The following is a description of a gene set: species: Mus musculus Mouse Gene Set: CUI_T_CELL_CD4_BAFF_RESPONSE_DN from publication Cui A, Huang T, Li S, Ma A, Pérez JL, Sander C, Keskin DB, Wu CJ, Fraenkel E, Hacohen N (PMID 38057668) Cytokines mediate cell-cell communication in the immune system and represent important therapeutic targets. A myriad of studies have highlighted their central role in immune function, yet we lack a global view of the cellular responses of each immune cell type to each cytokine. To address this gap, the authors created the Immune Dictionary, a compendium of single-cell transcriptomic profiles of more than 17 immune cell types in response to each of 86 cytokines (>1,400 cytokine-cell type combinations) in mouse lymph nodes in vivo. A cytokine-centric view of the dictionary revealed that most cytokines induce highly cell-type-specific responses. For example, the inflammatory cytokine interleukin-1β induces distinct gene programmes in almost every cell type. A cell-type-centric view of the dictionary identified more than 66 cytokine-driven cellular polarization states across immune cell types, including previously uncharacterized states such as an interleukin-18-induced polyfunctional natural killer cell state. Genes negatively differentially expressed in cell type: CD4+ T cell upon treatment with cytokine: BAFF in mouse lymph nodes in vivo., and this is the list of marker genes: Klf6, Hspa1b, Btg2, Hspa1a, Jun, Tsc22d3